Given this list of marker genes Tpx2, Thbs2, Cav2, Dlx3, Timp1, Spag5, Eps8 (epidermal growth factor receptor pathway substrate 8), Prl2c2, Fbxo32 (F-box protein 32), Il33 (interleukin 33), Prkg2, Errfi1, Cped1, Phex, F3, Il1r1, Slc37a3, Cenph, Clba1, B3gnt2, Rbpms, Jade2, Cd53, Hmga2, Csf2rb, Ptgs1, Anxa8, Sprr1a, Gfod1, Grem1, Arhgap6, Ado, Nceh1, Thbd, Mmd, Atp1a3, Smim36, Mgp, Dusp6, Dusp4, F2r, Plxdc1, Lbh, Brip1os, Ckap2l (cytoskeleton associated protein 2-like), Cdkn2d (NCBI Gene Id 12581), Anln, Rcan2, here is a description of the gene set: from publication Kuninger D, Kuzmickas R, Peng B, Pintar JE, Rotwein P (PMID 15475267) Peptide growth factors regulate cell fate by activating distinct signal transduction pathways that ultimately influence gene expression. Insulin-like growth factors (IGFs) play central roles in controlling somatic growth and participate in skeletal muscle development and regeneration. In cultured muscle cells, IGF action is critical both for maintaining viability during the transition from proliferating to differentiating myoblasts and for facilitating differentiation. By contrast, platelet-derived growth factor (PDGF) can sustain cell survival but inhibits differentiation. Here we examine the genetic programs that accompany IGF and PDGF action in myoblasts. Through analysis of high-density oligonucleotide arrays containing approximately 36,000 mouse probe sets, we identify 90 transcripts differentially induced by IGF-I, including 28 muscle-specific genes and 33 previously unannotated mRNAs, and 55 transcripts specifically stimulated by PDGF, including 14 unknowns. Detailed study of one IGF-induced mRNA shows that it encodes a protein related to a recently characterized repulsive guidance molecule postulated to regulate neuronal targeting during development. Our results demonstrate the power of transcriptional profiling for gene discovery and provide opportunities for investigating new proteins potentially involved in different aspects of growth factor action in muscle. species: Mus musculus Mouse Gene Set: KUNINGER_IGF1_VS_PDGFB_TARGETS_DN Genes down-regulated in cells (myoblast) by IGF1 vs PDGFB.